Given this list of marker genes CBL, TYRO3, NPC1, OAS3, CHMP4B, BST2, PABPC1, EPS15, SLC38A8, SCARB2, SELPLG, APOE, CD81, RAB43, GBP7 (NCBI Gene Id 388646), HAVCR1, DDX6, MIR221, GYPA, TOP2B (NCBI Gene Id 7155), IL32, SPCS1, PHB1, NR5A2, LDLR (low density lipoprotein receptor), PC, BSG, AVPR1B, SIGLEC1, JPT2, GAS6, MYH10, PVR, SIVA1, MOG, VPS37C, MYH9, TRIM62, IFITM3, SCARB1, SMC6, MRC1, RAB7A (NCBI Gene Id 7879), IFI16, EEF1A1, CNOT7, BCL2, IDE, VPS4A, ZC3H12A (NCBI Gene Id 80149), OAS1, CHMP4C (NCBI Gene Id 92421), TMEM41B, LARP1, NECTIN2, CR2, CHMP4BP1, CAV2 (NCBI Gene Id 858), CHMP4A, VCP, HSP90AB1, VAPA, TRIM6, SLPI, PRKN, SRPK2, FBXL2, ADARB1, TRIM21, CHMP1A, BANF1, PIKFYVE, CCR5, HS3ST5, TARBP2, PDE12, PCBP1, CR1, CLEC4G, ITGB3, CHMP1B, CLDN9, KPNA6, HLA-DRB1, PROX1, DDX3X, CD55, USP6NL, LAMP3, UVRAG, ATG5, RPSA, TRIM11, ITGB7 (integrin subunit beta 7), TOP2A, CD46, CD28, SLC1A5, MX1, LRRC15, PDCD6IP, AICDA, KIAA0319L, TMPRSS4, ICAM1, OAS2, SMC5, APOBEC3C, SHFL, CLEC4M, MIR222, CTBP1, MVB12A, NCAM1, FAM111A, STAU1, MAVS, CHMP7, CLDN6, ANPEP, FURIN, IFITM1, LGALS9, CXCR4, SRC, PLSCR1, HSPA1A, RAB1A, SLC52A2, RNASEK, APOBEC3H, HSPA1B, CDHR3, TNFRSF14, APOBEC3D, TRIM25, IFIH1, INSR, TBC1D20, LTF, DAG1, CCL5, ITGB1, APOBEC3G, IFIT5, ACE2, PPIB, CCNK (NCBI Gene Id 8812), CCL8, EFNB2, CCL2, MITD1 (microtubule interacting and trafficking domain containing 1), N4BP1, CHMP2B, DPP4, APOBEC3F, PPIA, EIF2AK4, VPS18, VAPB, HMGB1, OASL, CLEC5A, MVB12B, ZNFX1, RAD23A, VPS4B, SLC6A19, ITGB5, SLC20A2, CD4, CHMP5, CXCL8, CLDN1, DDX56, ZNF502, PCBP2, SMPD1, DYNLT1, SLAMF1, SLC3A2, CTSB, EFNB3, ITCH, PIK3C3, CSNK2B, DEK (DEK proto-oncogene), CD86, PPID, AXL, TRIM38, BTBD17, LAMP1, TPCN2, ISG15, SMARCB1, SLC7A1 (solute carrier family 7 member 1), VPS37B, RNASEL, ITGA5, RAB1B, ITGA2, EIF2AK2, TFRC, VPS37A, IFNB1 (NCBI Gene Id 3456), VAMP8, EPHA2, ZNF639, ZC3HAV1, AVP, WWP1, NUP153, NMT2, WWP2, SLC10A1, CD209 (NCBI Gene Id 30835), CD74 (CD74 molecule), F11R, CXADR, ATG16L1, NEDD4, CAV1, IFNL3, YTHDC2, FKBP6, TSG101 (NCBI Gene Id 89764), DDB1, SLC52A1, NECTIN3, CHMP6, CDK1, STOM (NCBI Gene Id 2040), ZBED1, LAMTOR5, LRSAM1, ITGAV, ILF3, EGFR, AGTR1, TRIM5, PCSK5, KPNA2, CTSL, TPCN1, TRIM28, NOTCH1, NFIA (nuclear factor I A), NUCKS1, ARL8B, TNF, TNIP1, XPR1, TRIM31, ITGB6, PPIH, PPIE, CHMP3, VPS37D, NECTIN1, TRIM15, APOBEC3A, P4HB, HMGA2, HYAL2, PKN2, IFI27, VPS28, KPNA3, CH25H, INPP5K (NCBI Gene Id 51763), IFIT1, ATG16L2, NRP1, ARK2N, CD80, ZFYVE1, CTBP2, TNFRSF4, SRPK1, TMEM39A, GPR15 (G protein-coupled receptor 15), NECTIN4, HACD3, TMPRSS2, RSAD2, CXCR6, GRK2, DDX5, HTR2A, FMR1, APOBEC3B, SERPINB3, LGALS1, CHMP2A, IFITM2, ISG20, ADAR, here is a description of the gene set: A set of processes which all viruses follow to ensure survival; includes attachment and entry of the virus particle, decoding of genome information, translation of viral mRNA by host ribosomes, genome replication, and assembly and release of viral particles containing the genome. Human Gene Set: GOBP_VIRAL_LIFE_CYCLE species: Homo sapiens